The following is a description of a gene set: Human Gene Set: RICKMAN_TUMOR_DIFFERENTIATED_WELL_VS_MODERATELY_DN species: Homo sapiens Propensity for subsequent distant metastasis in head and neck squamous-cell carcinoma (HNSCC) was analysed using 186 primary tumours from patients initially treated by surgery that developed (M) or did not develop (NM) metastases as the first recurrent event. Transcriptome (Affymetrix HGU133_Plus2, QRT-PCR) and array-comparative genomic hybridization data were collected. Non-supervised hierarchical clustering based on Affymetrix data distinguished tumours differing in pathological differentiation, and identified associated functional changes. Propensity for metastasis was not associated with these subgroups. Using QRT-PCR data we identified a four-gene model (PSMD10, HSD17B12, FLOT2 and KRT17) that predicts M/NM status with 77% success in a separate 79-sample validation group of HNSCC samples. This prediction is independent of clinical criteria (age, lymph node status, stage, differentiation and localization). The most significantly altered transcripts in M versus NM were significantly associated to metastasis-related functions, including adhesion, mobility and cell survival. Several genomic modifications were significantly associated with M/NM status (most notably gains at 4q11-22 and Xq12-28; losses at 11q14-24 and 17q11 losses) and partly linked to transcription modifications. This work yields a basis for the development of prognostic molecular signatures, markers and therapeutic targets for HNSCC metastasis. Down-regulated genes that vary between HNSCC (head and neck squamous cell carcinoma) groups formed on the basis of their level of pathological differentiation: well vs moderately differentiated tumors. from publication Rickman DS, Millon R, De Reynies A, Thomas E, Wasylyk C, Muller D, Abecassis J, Wasylyk B (PMID 18679425), and this is the list of marker genes: NUMB, NRG1, CYP26B1, LUZP1, PTP4A1, KLC1, AJAP1, AREG, TUBA4A, SFN, LRFN4, PKNOX1, KRT17, DMKN, S100A2, EHD4, KRT16, SPRR1B, PPARD, FAM83B, TEAD4, PLEK2, PTGS1, H2BC4, DUSP14, DEPDC7, CFAP251, RPS6KB2, CDCP1, KLHDC7B-DT (NCBI Gene Id 105373098), APLN, PSME3, NIPA2, CDKN1A, LCE3D, TTLL11, CT69, PI3, SDR9C7, RRAS2, AJUBA, MMP1, PPP2R2C, HOMER3, ETS2 (NCBI Gene Id 2114), KLK5, PRR9, TNS4, ARRDC4, H3-3B (H3.3 histone B), CDH22, ANGPT2, PDPN, AFAP1L1, MAP4, KRTDAP, WFDC12, AGPAT4, TUBB6, NRBF2, IFFO2, PAQR5, CDSN, KRT14, SQOR, DSG1, WFDC5, CDC42EP2, SLC28A3, CNGB1, SH2D5, HIF1A, DEFB4A, SPTLC1, IL22RA1, BNC1, GOLGA7B, KLK7, KCTD5, LIMA1, DEFB103B (defensin beta 103B), RAB31, KLK8, KLK10, MAPK6, OXSR1, LYPD5, ASCC3, KRT6B, SPRR2G, ARPC5L, ASPRV1, RNASE7, IPPK, CAV1, GPR39, CARD10, IL36RN, NOCT (nocturnin), GDPD2 (glycerophosphodiester phosphodiesterase domain containing 2), CCDC85C, IL24, GPR68, PERP, NEDD4, APBB2 (amyloid beta precursor protein binding family B member 2), USP15, IL1A, DNAJB5, IMPA2, CARHSP1, GJB2, TRAF3IP2